The following is a description of a gene set: Reticulated skin pigmentation Human Gene Set: HP_RETICULATED_SKIN_PIGMENTATION studied in species Homo sapiens, and this is the list of marker genes: KRT5, DKC1, KRT14, RBM28, TERT, NHP2, TINF2